Given this list of marker genes Slamf8, Tlr12, H2-Q10, Leprotl1, Gm19585, Slc15a3, Gbp6, Tapbpl (NCBI Gene Id 213233), Trav7d-4, Lag3, Gbp10 (NCBI Gene Id 626578), Irgm2, Dusp2, Stat1, Fasl, H2-T15, Tap1, Psmb9, H2-D1, Gm8810, Izumo1r, Gm13456, H2-DMb1, H2-T7, Lair1, Serping1, Rnf145, H2-Ea, Il10, Il21r, Ighm, C6, Ighd, Tent5c, H2-Ab1, Gm12250, Tgtp2, Tgtp1, Psmb8, Ubd, Dnase1l3, Nr4a3, Gbp11, Tnfrsf4, Tmem229b, Il27, Nkg7, Itk, Trim65, Cd27, Klrk1, Slc17a6, H2-T11-ps, Satb1, H2-T3, Klrc2, Mctp1, Crem, H2-DMa, Gpr174 (NCBI Gene Id 213439), Gm2427, Ccl4, Mag, H2-M3, Aif1, Il18bp, H2-T22, H2-Aa, B2m, C4b, Sh2d2a, Clec12a, Sla2, H2-Q2, Klrc1, Calhm6, Fcgr4, Tmem51, Ccl8, Trbv17, Gbp8, Fgl2, Crtam (cytotoxic and regulatory T cell molecule), C1qb, H2-T10, H2-K2, Art2a, Gbp4, Gbp3 (guanylate binding protein 3), Pdcd1, Ccm2, Plek, Usf1, Neurl3, Ccr8, Ralgps2, Gbp2, Igtp, Gvin-ps1, Cd8a, AW112010, Slc11a1, Psap, Trbv31, Etohd2, Nlrc5, Ly6i, H2-Eb1, Ifngr2, Gbp2b, C4a, Gvin-ps6, H2-Q1 (NCBI Gene Id 15006), P2ry10, Trac, here is a description of the gene set: The authors compared the cellular composition and gene expression profiles of responsive and nonresponsive tumors from BALB/cArc, BALB/cJAusb, and C57BL6/J mice before immune checkpoint blockade (ICB) and validated the findings in cohorts of patients with cancer treated with ICB antibodies. Mouse Gene Set: ZEMEK_IMMUNE_CHECKPOINT_BLOCKADE_OVARIAN_CANCER_RENCA_UP from publication Zemek RM, De Jong E, Chin WL, Schuster IS, Fear VS, Casey TH, Forbes C, Dart SJ, Leslie C, Zaitouny A, Small M, Boon L, Forrest ARR, Muiri DO, Degli-Esposti MA, Millward MJ, Nowak AK, Lassmann T, Bosco A, Lake RA, Lesterhuis WJ (PMID 31316010) Experiments were performed using Renca renal cell carcinoma cell lines. studied in species Mus musculus